The following is a description of a gene set: species: Homo sapiens Catalysis of the movement of a glycerophospholipid from the exoplasmic to the cytosolic leaflet of a membrane, using energy from the hydrolysis of ATP. Human Gene Set: GOMF_GLYCEROPHOSPHOLIPID_FLIPPASE_ACTIVITY, and this is the list of marker genes: ATP8B2, ATP8A2, ATP10B, ATP8A1 (NCBI Gene Id 10396), ATP11C, MFSD2A (MFSD2 lysolipid transporter A, lysophospholipid), ABCA4 (NCBI Gene Id 7815), ATP11A, ABCA3, ATP8B1, ABCB1, ATP10A